The following is a description of a gene set: Reduced ability to perceive painful stimuli. Impaired pain sensation Human Gene Set: HP_IMPAIRED_PAIN_SENSATION studied in species Homo sapiens, and this is the list of marker genes: MADD, SH3TC2, PWAR1, PNPT1, HERC2, CDKL5, TMEM218, PRPS1, NTNG1, GNB4, ELP1 (NCBI Gene Id 8518), DDHD1, IGF2, GDAP1, ATL1, ZFHX2, RFX7, NTRK1, H19, CLTCL1, MAGEL2, VCP, MKRN3, SCN11A, AIFM1, PRDM12, FBN1, CACNA2D1, TRIO, DEAF1, EBF3, GABBR2, LIFR, MECP2, ATXN1, PDXK, SPTLC1, SNORD115-1, MFN2, LMX1B, TDP1, CHAMP1, PWRN1, MCM3AP, ATL3, PDK3, PMP2, ABCA1, SCN9A, NEFL, HARS1 (NCBI Gene Id 3035), HDAC4, NGLY1, IARS2, DNM1L, SNUPN, SNORD116-1, HNRNPK, KDM5C (lysine demethylase 5C), SMC1A (structural maintenance of chromosomes 1A), FLII, SPTLC2, HSPB1, NPAP1, TRPM3, CCT5, RAI1, IQSEC2, JAG1, NGF, UBTF, GJB1, RFC1 (replication factor C subunit 1), SORD, PMP22, KCNQ1OT1, MPZ, ZEB2, SCYL1, SHANK3, GRIA3, HK1, MPV17